The following is a description of a gene set: from publication Busslinger GA, Weusten BLA, Bogte A, Begthel H, Brosens LAA, Clevers H (PMID 33691112) Human Gene Set: BUSSLINGER_GASTRIC_LYZ_POSITIVE_CELLS studied in species Homo sapiens, and this is the list of marker genes: C16orf89, ETV5, ERGIC1, RPL5, PIGR, EEF2, RPL36, RPLP0, SLPI, RPS21, REG1A, RPL18A, C6orf58, FUT9, SOX9, ATP6V1G1, RPS10, RPL10A, RPS2, RPS9, PPP1R1B, EEF1G, RPL37A, RPS4X, RPL11, ADIRF, RPS18, RPS15 (ribosomal protein S15), RPL34, RPL12, FAM3B, RPL28, EEF1A1, MMP1, CST3, PABPC1, RPL7, RPL23, RPL10, RPL15, NR4A1, AQP5, LYZ, EGR1, RPL13AP3, RPS13, TFF2, RPL7A, CD81, RPS3, RPL23A, PGC, GLUL, GOLM1, FOS, NOP53, RPS8, ANKRD22, ELAPOR1, RPL9, FNDC3B, GP2, RPL30, RPL19, RPL37 (ribosomal protein L37), RPL6, CXCL17, RPS14, RPS23, RPL39, SLC12A2, RPS5, RPL13, TM9SF3, RPL18, SPDEF, RACK1, RPS20, RPS12, RPS7, ADH1C, MSMB, RPL35A, RPL32, CD24, RPS6, RPL14, RPL29, CLU, RPL17, EEF1B2, FMOD, AGR2, TM4SF1, CREB3L1, RPS28, RPS3A, RPL31, PKDCC, TPT1, RPL41, RPS27, RPL3, RPL35, ANXA5, MUC6, RPL26, CDCA7, SEZ6L2, ZDHHC9, RPS15A